Given this list of marker genes MYL2, CSRP3, MYF5, CAVIN4, XIRP1, SMTNL1, HSPB1, SMPX, MYOT, FHL1, FHL2, CASQ1, NFATC2, TPM2, ATP2A1, ITGB1BP2, ANKRD2, CRYAB, PDLIM1, CASQ2, here is a description of the gene set: Human Gene Set: CHEMELLO_SOLEUS_VS_EDL_MYOFIBERS_UP BACKGROUND: Skeletal muscle is a complex, versatile tissue composed of a variety of functionally diverse fiber types. Although the biochemical, structural and functional properties of myofibers have been the subject of intense investigation for the last decades, understanding molecular processes regulating fiber type diversity is still complicated by the heterogeneity of cell types present in the whole muscle organ. METHODOLOGY/PRINCIPAL FINDINGS: We have produced a first catalogue of genes expressed in mouse slow-oxidative (type 1) and fast-glycolytic (type 2B) fibers through transcriptome analysis at the single fiber level (microgenomics). Individual fibers were obtained from murine soleus and EDL muscles and initially classified by myosin heavy chain isoform content. Gene expression profiling on high density DNA oligonucleotide microarrays showed that both qualitative and quantitative improvements were achieved, compared to results with standard muscle homogenate. First, myofiber profiles were virtually free from non-muscle transcriptional activity. Second, thousands of muscle-specific genes were identified, leading to a better definition of gene signatures in the two fiber types as well as the detection of metabolic and signaling pathways that are differentially activated in specific fiber types. Several regulatory proteins showed preferential expression in slow myofibers. Discriminant analysis revealed novel genes that could be useful for fiber type functional classification. CONCLUSIONS/SIGNIFICANCE: As gene expression analyses at the single fiber level significantly increased the resolution power, this innovative approach would allow a better understanding of the adaptive transcriptomic transitions occurring in myofibers under physiological and pathological conditions. species: Mus musculus Genes up-regulated in type 1 (soleus) vs type 2B (EDL) myofibers. from publication Chemello F, Bean C, Cancellara P, Laveder P, Reggiani C, Lanfranchi G (PMID 21364935)